The following is a description of a gene set: species: Mus musculus The series of molecular signals generated as a consequence of a brain-derived neurotrophic factor receptor binding to one of its physiological ligands. Mouse Gene Set: GOBP_BRAIN_DERIVED_NEUROTROPHIC_FACTOR_RECEPTOR_SIGNALING_PATHWAY, and this is the list of marker genes: Epha3, Epha1, Ntrk3, Ntrk2, Mst1r, Kdr, Insr, Erbb2, Fgfr1, Vps13a, Tiam1, Epha4, Fgfr3, Atp1a3, Tyro3, Ephb1, Ephb3, Ddr1, Fgfr4, Musk, Flt1, Fgfr2, Flt3, Kit, Ntrk1, Flt4, Csf1r, Met, Ror2, Epha7, Tie1, Epha5, Pdgfrb, Erbb4 (NCBI Gene Id 13869), Pdgfra, Epha6, Tek, Slc9a6, Slc2a4, Ddr2, Nfatc4, Epha2, Mertk, Ret, Egfr (NCBI Gene Id 13649), Axl, Epha8, Fstl4, Epha10, Igf1r, Rapgef2, Ros1, Ltk, Ephb2, Alk, Ephb4, Insrr (NCBI Gene Id 23920)